The following is a description of a gene set: Human Gene Set: HP_INTRA_ORAL_HYPERPIGMENTATION studied in species Homo sapiens Increased pigmentation, either focal or generalized, of the mucosa of the mouth. Intra-oral hyperpigmentation, and this is the list of marker genes: USP8, ABCD1, USP48, NR3C1, ATRX, MTX2, BRAF, CDH23, TP53